The following is a description of a gene set: Dendritic cells (DCs) and macrophages (MPs) are important for immunological homeostasis in the colon. We found that F4/80hi CX3CR1hi (CD11b+CD103-) cells account for 80% of mouse colonic lamina propria (cLP) MHC-IIhi cells. Both CD11c+ and CD11c- cells within this population were identified as MPs based on multiple criteria, including a MP transcriptome revealed by microarray analysis. These MPs constitutively released high levels of IL-10 at least partially in response to the microbiota via an MyD88-independent mechanism. In contrast, cells expressing low to intermediate levels of F4/80 and CX3CR1 were identified as DCs, based on phenotypic and functional analysis and comprise three separate CD11chi cell populations: CD103+CX3CR1-CD11b- DCs, CD103+CX3CR1-CD11b+ DCs and CD103-CX3CR1intCD11b+ DCs. In non-inflammatory conditions, Ly6Chi monocytes differentiated primarily into CD11c+, but not CD11c- MPs. In contrast, during colitis, Ly6Chi monocytes massively invaded the colon and differentiated into pro-inflammatory CD103-CX3CR1intCD11b+ DCs, which produced high levels of IL-12, IL-23, iNOS and TNF. These findings demonstrate the dual capacity of Ly6Chi blood monocytes to differentiate into either regulatory MPs or inflammatory DCs in the colon, and that the balance of these immunologically antagonistic cell types is dictated by microenvironmental conditions. from publication Rivollier A, He J, Kole A, Valatas V, Kelsall BL (PMID 22231304) species: Homo sapiens Genes down-regulated in macrophages versus dendritic cells. Human Gene Set: GSE27859_MACROPHAGE_VS_DC_DN, and this is the list of marker genes: BTBD2, KLHDC7A, BSCL2, RPP25, TSPAN16, CEBPB, ZBTB34, CLCNKB, ARAP1, SERINC2, RGL3, POLR1HASP, CPD, LRPAP1, PXDN, ZDHHC8BP, DAG1, TRIM25, HSD17B14, ZDHHC8, KLHDC8B, SEPTIN3, ZNF630, CD9, ANKK1, AGPAT4, MECP2, NRF1, PELI3, TANC2, NKAPL, ARHGAP24, ACSL1, ADAMTSL4, SHANK3 (SH3 and multiple ankyrin repeat domains 3), MFHAS1, MIR191, NIPSNAP3B, UTS2R, TRH, GPC1, TMEM74, CTSD, SLC39A11, SCCPDH, HMGN2P18, SCN1A, CEP72, GNRH2, SNX29P2, PDK4, GJD4, SLC12A6, HMGN4, CHRM5, RNF149, WFDC3 (NCBI Gene Id 140686), LGALS3, SMARCD3, SLC27A1, PCOLCE2, HDHD3, CHRNG, KMT2D, LYSMD1, TSPAN3, OR8I2, LZTS3, ZFAND6, ABHD5, C6orf47, SETD5, ALDH8A1, TAF4, BSX, LTB, RBP1, DND1, FRS3, OR52K2, CPT1A, PLVAP, ACADVL, MIR31, MGST1, CNPY3 (NCBI Gene Id 10695), KCNJ5, MADCAM1, EGLN2, HTR3E, WBP1L (WW domain binding protein 1 like), DMBX1, KLHL35, INF2, AGPAT2, ZFYVE26, SLC31A2, ZAR1L, HAPLN2, SIK2, APOC1, CRIPT, IGSF9B, DET1, PARP15, LGI4 (NCBI Gene Id 163175), DHRS7C, ATN1, MORC2-AS1, ACP5, SKP1, RPRML, ZBTB47, DCP1B, PLIN2 (perilipin 2), C6, LCE3B, TNRC6C, SNX27, WFDC5, GRIN3B, TTLL8, STMN1 (NCBI Gene Id 3925), EMID1, KCNA7, CD68, LDB3, CYP27A1, SIRT2, TRMT112, AICDA, IL10RB, PON1, SIK3, NRIP2, WIZ, UBXN11, GARIN1B, CCDC38, PPP1R15B, ENTREP3, NR1H3, HCAR3, AURKC, APH1B, PHF24, VEGFB, ANKRD42, FAM9B, TAFA2, CALML3, KLHL33, H2AC12, KCNC4, GNAS, RBM14, IMPA2 (inositol monophosphatase 2), FGF17 (fibroblast growth factor 17), PCDHB3, FTH1P5, PKNOX2, RAD51B, CYGB (NCBI Gene Id 124510), DSG4, ICAM2 (intercellular adhesion molecule 2), UBE2R2, SLC14A2, NPFFR2, CLN3, PKLR, SVIL, HMGB3P1, USP49, CYTH1, CLIP4, CABLES1, SLC8B1, POU5F2, TMEM79, SGCE, TBC1D9, RAPGEFL1, FTH1, SCARNA8, CBX7, FAM89A, KIF1B, FBXO46, IL20RB, SLC25A18, UNC5CL, LTA4H, RSPH3, OR4D6, NPHP4